Given this list of marker genes Aldh3a2, Rgn, Bphl, Mup5, Cat, Inpp5b, Rdh16, Zap70, Klkb1, 4931406C07Rik, Vnn1, Otc, Idi1, Tmem176a, Sult1b1, Car3, Noct, Serpina12, Igfals, Aldob, Trp53inp2, Iigp1, Mix23, Akr1c6, Pdzk1, Cpt2, Ostc, G0s2, Lasp1, Sult5a1, Phlda1, Ehhadh, Fmo1, Reep6, Hsd17b10, Aldh1a1, Xist, Cyp2b13, Slc31a1, Inmt, Cd1d1, Fabp1, S100a10, Mup4 (major urinary protein 4), Mup3, Ifi27, Lyz2, here is a description of the gene set: Top genes down-regulated in liver tissue from mice with knockout of ZMPSTE24. Zmpste24 (also called FACE-1) is a metalloproteinase involved in the maturation of lamin A (Lmna), an essential component of the nuclear envelope. Both Zmpste24- and Lmna-deficient mice exhibit profound nuclear architecture abnormalities and multiple histopathological defects that phenocopy an accelerated ageing process. Similarly, diverse human progeroid syndromes are caused by mutations in ZMPSTE24 or LMNA genes. To elucidate the molecular mechanisms underlying these devastating diseases, we have analysed the transcriptional alterations occurring in tissues from Zmpste24-deficient mice. We demonstrate that Zmpste24 deficiency elicits a stress signalling pathway that is evidenced by a marked upregulation of p53 target genes, and accompanied by a senescence phenotype at the cellular level and accelerated ageing at the organismal level. These phenotypes are largely rescued in Zmpste24-/-Lmna+/- mice and partially reversed in Zmpste24-/-p53-/- mice. These findings provide evidence for the existence of a checkpoint response activated by the nuclear abnormalities caused by prelamin A accumulation, and support the concept that hyperactivation of the tumour suppressor p53 may cause accelerated ageing. from publication Varela I, Cadiñanos J, Pendás AM, Gutiérrez-Fernández A, Folgueras AR, Sánchez LM, Zhou Z, Rodríguez FJ, Stewart CL, Vega JA, Tryggvason K, Freije JM, López-Otín C (PMID 16079796) species: Mus musculus Mouse Gene Set: VARELA_ZMPSTE24_TARGETS_DN